The following is a description of a gene set: Mouse Gene Set: GOBP_APICAL_JUNCTION_ASSEMBLY The formation of an apical junction, a functional unit located near the cell apex at the points of contact between epithelial cells composed of the tight junction, the zonula adherens junction and the desmosomes, by the aggregation, arrangement and bonding together of its constituents. species: Mus musculus, and this is the list of marker genes: Rac1, Cldn3, Fbf1, Mpp7, Cldn34c6, Cldn34c5, Marveld3, Cldn34a, Frmpd2, Ocln, Wdr1, Cldn34b1, Cldn10, Fzd5, Gja1, Pkp2, Rps6, Samt2b, Dsg3, Aloxe3, Cldn17, Prkaca (protein kinase, cAMP dependent, catalytic, alpha), Gpbar1 (NCBI Gene Id 227289), Cdh5, Pkn2, Cldn34c4, Cldn16, Ramp2, Cgn, Cldn5, Dlg5, Cldn23, Cldn34b4, Srf, Cldn7, Ocel1, Snai2, Actn4, Rock1, Dlg1 (NCBI Gene Id 320792), Myo1c, Micall2 (MICAL-like 2), Cldn14, Rock2, Cldn9, Ikbkb, Epha2, Acvrl1 (activin A receptor, type II-like 1), Tjp1, Cldn2, Abi2, Esam, Marveld2, Cldn8, Rhoc, Pof1b, Nphp1 (NCBI Gene Id 53885), Cldn4, Cldn15, Ctnna1, Cldn34c3, Cldn19 (claudin 19), Cldn34c2, Tnf, Rhoa (NCBI Gene Id 51787), Prkcz2, Rps6-ps4, Itgb1, Cldn34b2, Cldn34b3, Samt1b, Alox12b, Ect2, Pdcd6ip, Samt2, Gdf2 (growth differentiation factor 2), Cldn24, Afdn, Cldn34d, Prkch, Cldn6, Pak2, Vcl, Rab13, Cldn18, Tbcd, Samt1d, Nphp4, Samt4, Arl2, Slc39a9, Cldn11 (NCBI Gene Id 18417), Cldn34c1, Pard3, Nedd4l, Cldn1, Wnt11, Grhl2, Pecam1, Cldn13, Samt3, Cdh1, Il17a, F11r, Snai1, Cldn22